Given this list of marker genes FGF4, FGF9, FGF6, FGF1, FGF5, FGF2, FGF20, FGF23 (NCBI Gene Id 8074), FGF8, FGFR1, FGF17, here is a description of the gene set: Human Gene Set: REACTOME_SIGNALING_BY_ACTIVATED_POINT_MUTANTS_OF_FGFR1 Signaling by activated point mutants of FGFR1 studied in species Homo sapiens